Given this list of marker genes BMAL1, CLEC6A, RPL14, SERPINA1, SLC34A2, LAMA3, LYZ, PAIP1, TRIM59, DEFA6, PRSS30P, CASP12, PGLYRP1, HLA-DMA, HLA-DMB, SLC5A8, MT1X, HLA-DQA2, DEFA5, ITGA8, here is a description of the gene set: Human Gene Set: TUOMISTO_TUMOR_SUPPRESSION_BY_COL13A1_UP Genes up-regulated in small intestine tissue from transgenic mice expressing a mutant form of COL13A1, compared to normal controls. Epithelial cells of mucosal surfaces are critical for maintaining immune homeostasis by aiding in the discrimination of pathogenic and commensal microorganisms and modulating the activities of antigen-presenting cells and lymphocytes. Functional breakdowns resulting in chronic infection and inflammation are associated with the development of hematologic and solid neoplasms for which detailed pathogenetic mechanisms are poorly understood. Mice heterozygous for a transgene Col13a1(del) expressing a mutant collagen XIII developed clonal mature B-cell lineage lymphomas originating in mesenteric lymph nodes (MLN). The tumors were associated with T cells and macrophages. The incidence of disease was reduced 2-fold in transgenic mice raised under specific pathogen-free conditions, suggesting a role for infectious agents. The lymphomas did not express the mutant collagen XIII, indicating that its influence on tumorigenesis was B-cell extrinsic and likely to be associated with collagen XIII-positive tissues drained by the MLN. Studies of the small intestines of transgenic mice showed that the subepithelial basement membranes (BM) were highly abnormal and that they exhibited heightened expression of genes involved in immune responses. These results define collagen XIII-dependent maintenance of the intestinal BM as a previously unappreciated component of immune responses and a critical determinant of cancer susceptibility. species: Mus musculus from publication Tuomisto A, Sund M, Tahkola J, Latvanlehto A, Savolainen ER, Autio-Harmainen H, Liakka A, Sormunen R, Vuoristo J, West A, Lahesmaa R, Morse HC 3rd, Pihlajaniemi T (PMID 19074901)